The following is a description of a gene set: from publication Elvidge GP, Glenny L, Appelhoff RJ, Ratcliffe PJ, Ragoussis J, Gleadle JM (PMID 16565084) Genes up-regulated in MCF7 cells (breast cancer) after knockdown of both HIF1A and HIF2A by RNAi. Studies of gene regulation by oxygen have revealed novel signal pathways that regulate the hypoxia-inducible factor (HIF) transcriptional system through post-translational hydroxylation of specific prolyl and asparaginyl residues in HIF-alpha subunits. These oxygen-sensitive modifications are catalyzed by members of the 2-oxoglutarate (2-OG) dioxygenase family (PHD1, PHD2, PHD3, and FIH-1), raising an important question regarding the extent of involvement of these and other enzymes of the same family in directing the global changes in gene expression that are induced by hypoxia. To address this, we compared patterns of gene expression induced by hypoxia and by a nonspecific 2-OG-dependent dioxygenase inhibitor, dimethyloxalylglycine (DMOG), among a set of 22,000 transcripts, by microarray analysis of MCF7 cells. By using short interfering RNA-based suppression of HIF-alpha subunits, we also compared responses that were dependent on, or independent of, the HIF system. Results revealed striking concordance between patterns of gene expression induced by hypoxia and by DMOG, indicating the central involvement of 2-OG-dependent dioxygenases in oxygen-regulated gene expression. Many of these responses were suppressed by short interfering RNAs directed against HIF-1alpha and HIF-2alpha, with HIF-1alpha suppression manifesting substantially greater effects than HIF-2alpha suppression, supporting the importance of HIF pathways. Nevertheless, the definition of genes regulated by both hypoxia and DMOG, but not HIF, distinguished other pathways most likely involving the action of 2-OG-dependent dioxygenases on non-HIF substrates. Human Gene Set: ELVIDGE_HIF1A_AND_HIF2A_TARGETS_UP species: Homo sapiens, and this is the list of marker genes: GCH1, RPP40, FLAD1, SLC29A1, STX3, TOR3A, SPAG1, RFK, RMC1, RET, SOCS2, HSPA4, RRP12, RIOX1, POLR3K, SLC25A44, GYG1, CCDC86, SLC24A3, CCND3, GABBR2, CORO1A, WDR77, AREL1, TAF9B, ABCF2, RRS1, SLC35B1, ATP6V0A2, ADAT1, SLC5A6, CHUK (component of inhibitor of nuclear factor kappa B kinase complex), CHKA, AUNIP, IDH3A, HSPH1, RPP25, SRM, LSG1, SLC35C1, OSTM1